The following is a description of a gene set: Any process that modulates the frequency, rate or extent of autophagic cell death. Mouse Gene Set: GOBP_REGULATION_OF_AUTOPHAGIC_CELL_DEATH species: Mus musculus, and this is the list of marker genes: Atg5, Atp6v0c, Dapk1 (death associated protein kinase 1), Laptm5, Trem2, Bmf